The following is a description of a gene set: from publication Chen Y, Wang X (PMID 31504780) Mouse Gene Set: MIR_7212_3P studied in species Mus musculus Genes predicted to be targets of miRBase v22 microRNA mmu_miR_7212_3p in miRDB v6.0 with MirTarget v4 prediction scores > 80 (high confidence targets)., and this is the list of marker genes: Bcor, Fthl17e, St8sia1, Chic1, Rab18, Lrba, Sos1, Senp7, Klhl2, Pgm2l1, Smyd3, Caap1, Mgp, Smad7, Il1rl1, Grm4, Ddx5, G2e3, Fam131a (family with sequence similarity 131, member A), Emcn, Wdfy3 (WD repeat and FYVE domain containing 3), Eif4e2, Topors (topoisomerase I binding, arginine/serine-rich), Rprd1a, Jak2, Pfn1, Twf1, Ctsc, Satb2, Snapc1, Rnf182, Myt1, Rnf126, Mecom, Meis2, Phip, Tdpoz1, Fam219a, Smim13, Akna, Prkg1 (protein kinase, cGMP-dependent, type I), H2-Q1, Cetn2 (NCBI Gene Id 93784), Ccdc92, Ttbk2, Rsbn1, Terb2, Ythdc1, Kif13a, Dach1, Akap8, Acly, Phtf2, Trhde, Rfx7, Eya4, Ctnna3, Prl7a1, Fchsd1, Zxdb, Dspp, Smndc1, Zfx, Mapk9, Pax3, Trp53inp1, Ncoa4, Zdhhc21, Ptgr1, Zbtb18, Cfap126, Matn1, Nip7, Mdh1, Aldh3a2, Csmd1, Ncoa5, Trappc10, Pabpn1l (NCBI Gene Id 382035), Syncrip, Aff4, Spop, Agtr1b, Rgn, Med14, Midn, N4bp2l2, Mapk8, Plod2, Hcn1, Nfat5, Fbxl5, Rskr, Slc38a2, Krit1, Tmem183a, Oaz2, Cckar, Sptlc1, Klrg1, Ywhaq, Zmynd11, Rbpj (NCBI Gene Id 791349), En2, Ptpn5, Pigh, Gtf3c4, Zcchc2, Mad2l1, Tesmin, Zfp367, Fign, Prkab2, Taok1, Nufip2, Mbnl3, Col27a1, Fam53c, Elf4, Unc80, Zfp341, Pgm1, Pfkfb2 (6-phosphofructo-2-kinase/fructose-2,6-biphosphatase 2), Prkci, Cxxc4, Epha5, Mcam, Ptgfrn, Vwc2l, Fthl17c, Hmgb1, Fam76a, Cnot7, Nfatc2ip, Scg2, Dclre1b, Mtf2, Pabir1, Tusc1, Fgf10, Tbc1d15, Med1, Fbxo38, Bcl2l11, Zfp617, Crkl, Kif3c, Itih5, Rnf38, Yy2, Pawr, Fndc3b, Tent5a, Nhlrc3, Greb1l, Rspry1, Stk3 (serine/threonine kinase 3), Mzt1, Gfod1, Ppig, Cebpg, Nol4, Eny2 (ENY2 transcription and export complex 2 subunit), Slc17a8, Scai, Aopep, Leprotl1, Cdh2, Nr4a3, Uri1, Zfr, Secisbp2l, Ganab, Fras1, Cables1, Slc22a23, Vps13d, Gpr45, Foxa2, Mb21d2, Decr1, Rab3ip, Phkb, Zfp280c, Pptc7, Blcap, St8sia4, Tmc7, Mdga2, Plscr1, Tfcp2, Cntnap2, Bag5, Ccp110, Ube2v2, Unc5c, Kin, Tenm2, Cyrib, Iffo2, Hivep1, Slc35g2, Epha4, Galr1, Zbtb1, Dzank1, Foxo1, Lonrf1, Pnpla8, Slain2, Marf1, Git2, Prdm16, Tmcc2, Dnal1, Tmem108, Pi15, Mtx3, Selenot (selenoprotein T), Dcaf12, Rbms2, Frg2f1, Coq10b, Rora, Dusp10, Dip2b, Smad2, Lpp, Fip1l1, Zfp711, Pde3a, Kdelr2, Gda, Evi5, Nek7, Dtna, Npas3, Mrpl39, Zfhx4, Pknox2, Ctbp2, Rbmx, Dynlt5, Crmp1, Mycs, Snap91, Tgfb2, Nr2f2, Taf9b, Cdk17, Gng4 (NCBI Gene Id 14706), Mamdc2, Tnrc6b, AI182371, Mblac2, Tfap2c, Ubxn7, Fthl17b, Trpc5, Ddx43, Mef2c (NCBI Gene Id 71350), Tmem200a, Ipo5, Gtf2a1, Aqp4, Bnip3, Fam53a, Mapre1, Stxbp2, Neurl1b, Bicd2, Yipf6 (NCBI Gene Id 77929), Sh3gl3, Trp53bp2, Pdpk1, Ghr, Pyurf, Atp6v1a, Arid2, Galnt7, Slc30a1, Dyrk1a, Sema5a, 4930563E22Rik, Maged1, Dll1, Npy, Ift88, Plag1, Evc2, Lfng